Given this list of marker genes WNK3, ACTN4, TESC, SCN1B, CHP1, FGF13 (fibroblast growth factor 13), WNK2, here is a description of the gene set: Any process that activates or increases the frequency, rate or extent of sodium ion transmembrane transporter activity. studied in species Homo sapiens Human Gene Set: GOBP_POSITIVE_REGULATION_OF_SODIUM_ION_TRANSMEMBRANE_TRANSPORTER_ACTIVITY